Given this list of marker genes ANXA2, FOXP1, P2RX5, FBN1, FBXW7, CLDN18, LILRB1, TNFSF11, PAFAH1B1, ATP6AP1, SLC9B2, TYROBP, SIGLEC15 (sialic acid binding Ig like lectin 15), GPR68, SRC (SRC proto-oncogene, non-receptor tyrosine kinase), LTF, NOTCH2, LRRK1, FAM20C, here is a description of the gene set: The process whose specific outcome is the progression of a bone cell over time, from initial commitment of the cell to a specific fate, to the fully functional differentiated cell. Human Gene Set: GOBP_BONE_CELL_DEVELOPMENT studied in species Homo sapiens